Given this list of marker genes NRG3, NRG2, ERBB3 (NCBI Gene Id 619500), EGF, NRG4, PIK3R1, NRG1, ERBB2, ERBB4, GRB2, EGFR, GAB1, EREG, BTC, HBEGF, PIK3CA (phosphatidylinositol-4,5-bisphosphate 3-kinase catalytic subunit alpha), here is a description of the gene set: Human Gene Set: REACTOME_PI3K_EVENTS_IN_ERBB2_SIGNALING species: Homo sapiens PI3K events in ERBB2 signaling